Given this list of marker genes PRDX6, PRDX1, NUDT2, TXN2, P4HB, TXNRD2, PRDX5, CCS, ATOX1, CYCS, NCF1, PRDX2, GSR, NOX4, GPX1, CYBB, SOD1, GPX2, GSTP1, NCF2, PRDX3, ATP7A, TXN, CAT, TXNRD1, GPX7, NCF4, GPX8, CYBA, ERO1A, SOD2, AQP8, GPX6, GPX5, SOD3, NOX5, GPX3, here is a description of the gene set: Reactive oxygen species such as superoxide (O2.-), peroxides (ROOR), singlet oxygen, peroxynitrite (ONOO-), and hydroxyl radical (OH.) are generated by cellular processes such as respiration and redox enzymes and are required for signaling yet they are damaging due to their high reactivity. Aerobic cells have defenses that detoxify reactive oxygen species by converting them to less reactive products. Superoxide dismutases convert superoxide to hydrogen peroxide and oxygen. Catalase and peroxidases then convert hydrogen peroxide to water.<br>Humans contain 3 superoxide dismutases: SOD1 is located in the cytosol and mitochondrial intermembrane space, SOD2 is located in the mitochondrial matrix, and SOD3 is located in the extracellular region. Superoxide, a negative ion, is unable to easily cross membranes and tends to remain in the compartment where it was produced. Hydrogen peroxide, one of the products of superoxide dismutase, is able to diffuse across membranes and pass through aquaporin channels. In most cells the primary source of hydrogen peroxide is mitochondria and, once in the cytosol, hydrogen peroxide serves as a signaling molecule to regulate redox-sensitive proteins such as transcription factors, kinases, phosphatases, ion channels, and others. Hydrogen peroxide is decomposed to water by catalase, decomposed to water plus oxidized thioredoxin by peroxiredoxins, and decomposed to water plus oxidized glutathione by glutathione peroxidases. studied in species Homo sapiens Reactome Pathway: Detoxification of Reactive Oxygen Species part of: Cellular response to chemical stress